The following is a description of a gene set: The process whose specific outcome is the progression of the skin over time, from its formation to the mature structure. The skin is the external membranous integument of an animal. In vertebrates the skin generally consists of two layers, an outer nonsensitive and nonvascular epidermis (cuticle or skarfskin) composed of cells which are constantly growing and multiplying in the deeper, and being thrown off in the superficial layers, as well as an inner vascular dermis (cutis, corium or true skin) composed mostly of connective tissue. Mouse Gene Set: GOBP_SKIN_DEVELOPMENT studied in species Mus musculus, and this is the list of marker genes: Itga6, Dbi, Tmem79, Acer1, Ctsl, Ncoa3, Ptges3, Acvr1b, Krt86 (keratin 86), Gpr89, Cstdc5, Zfp36 (zinc finger protein 36), Krt83, Pnpla1, Plec, Dicer1, Cstdc3, Wnt10b, Gba1, Ppp3ca, Krt1, Krt73, Lgr5, Tcf7l1, Dlx3, Sprr2g, Krtap21-1, Mfsd12, Bcl11b, Gli2, Aloxe3, Notch1, Barx2, Rbpj, Cd109, Krt7, Nf1, Krt6b, Apc, Lrp4, Shh, Alx4, Krt17, Vangl2, Sos1, Vps33b, Tnfsf13b, Sprr2b, Hoxa7, Hpse, Col5a2 (collagen, type V, alpha 2), Ngfr, Sox21, Pla2g10, Sprr1a, Krt78, Slc39a7, Ovol2 (NCBI Gene Id 69059), Alox8, Nsdhl, Igfbp5, Col1a2, Stfa2, Krt10, Sprr2h, Krt2, Jup, Wdr48, St14, Vdr, Txnip, Csta2, Sprr2d (small proline-rich protein 2D), Ahdc1, Snai1, Traf3ip2, Slc2a10, Stard7 (NCBI Gene Id 99390), Grhl2, Smarca4, Akt1, Numa1, Wnt10a, Tsg101, Sgpp1, Tfap2b, Tgfb2, Pax6, Ltb, Gata6, Smo, Hrnr, Myo5a, Krt79, Pkp3, Ercc2, Krt27, Krtap6-2, Prkch, Cldn1, Fras1, Anxa1, Pkp1, Fgfr2, Cbx7, Krt4, Gm5414, Ivl, Krt85, Scd1, Dact2, Atp7a, Il18, Col5a1, Kprp, Lhx2, Flnb, Gak, Krt75, Apcdd1, Nom1, Dhcr24, Cldn13, Col3a1, Itga2, Lce1a2 (late cornified envelope 1A2), Srsf6, Gjb3, Nme2, Fst, Trps1, Rock1, Foxn1, Slc39a2, Ldb2, Psap, Loricrin, Fuz, Foxe1, Cstdc4, Il1a, Krt36, Itgb4, Csta3, Tgm3, Extl3, Hdac1, Nfkbiz (nuclear factor of kappa light polypeptide gene enhancer in B cells inhibitor, zeta), Ldb1, Arrdc3, Col1a1, Sprr2f, Ext1, Adamts2, Edar, Sprr2k, Etv4, Cdkn2a, Tfap2a, Sox9, Zfp36l1, Fzd6, Opn3, Krt77, Casp3, Med1, Sav1, Cers3, Krt84, Flg2, Met, Ptgs1, Ryr1, Alox12b, Sprr1b, Eda, Wnt5a, Stfa2l1, Ovol1, Comp, Ppl, Tnf, Srf, Rock2, Krt14, Msx2, Ugcg, Asprv1, Krt5, Clic4, Fam210b, Asah1, Elovl1, Errfi1, Atp8a2, Norad, Gm5478, Naglu, Yap1, Enpp1, Cyp26b1, Tmprss13 (NCBI Gene Id 546127), Cyp27b1, Lamc1, Trp63, Lce1g, Gorab, Sufu, Tmprss11f, Krt9, Cysrt1, Runx3, Krt28, Zmpste24, Krt6a, Cdh1, Ezh2, Scel, Stmn1, Dkk4, Ctnnb1, Sfn, Runx1, Sharpin, Epha2, Cdh3, Tcf7l2, Foxc1, Lncpint, Mreg, Itga3, Ppard, Ubn1 (NCBI Gene Id 68719), Krt16, Macroh2a2, Fa2h, Wnt7a, Ap3b1, Pphln1, Exph5, Wnt16, Dnase1l2, Cdsn, Lats2, Trpv1, Il17a, Sostdc1 (NCBI Gene Id 66042), Kdf1, Cnfn, Sprr4, Cstdc6, Psen1, Fzd3, Mysm1 (myb-like, SWIRM and MPN domains 1), Krt76, Inhba, Map2k1, Col6a1, Lsr, Fgf10, Sprr3, Krt81, Mafb, Krt80, Dsg4, Ncor1, Myd88, Ptch2, Pou2f3, Dkk1, Evpl, Grhl1, Chuk, Gprc5d, Gal, Nsun2, Gnasas1, Alox12, Krt74, Tradd, Zdhhc21, Itgb6, Tfap2c, Pou3f1, Smad4, Palld, Fosl2 (fos-like antigen 2), Macroh2a1, Lama5, Krt90, Reg3a, Tnfrsf19, Celsr1, Flg, Pkd1, Grhl3, Dll1, Pdgfa, Cldn4, Foxq1, Hoxc13 (homeobox C13), Tgm1, Stfa1, Fermt1, Prss8, Edaradd, Slc27a4, Ash1l, Bcr, Kazn, Dsc1, Sprr2e, Pum2, Cdkn1a, Hdac3, Gsdma3, Csta1, Abca12, Reg3g, Sox18, Krt87, Foxi3, Lats1, Rela, Krt72, Irf6, Krt82, Psen2, Stk4, Hdac2, Ptgs2, Abcb6, Intu, Egfr, Lgr4, Slitrk5, Pias4, Klf4 (Kruppel-like transcription factor 4 (gut)), Krt25, Sprr2i, Krt71, Ncor2, Ripk4, Ift74, Trpc4ap, Zfp750, Fgf7, Stfa3, Madcam1, Krtap6-5, Dsp, Bcl2, Gnas